The following is a description of a gene set: species: Homo sapiens part of: DAG1 glycosylations Reactome Pathway: DAG1 core M1 glycosylations Protein-linked O-mannose glycans are initiated by the covalent attachment of mannose to serine and threonine residues in the protein via alpha-linkages. Core M1 glycans consist of all O-mannose glycans in which O-mannose is extended with beta-1,2-linked N-acetylglucosamine (GlcNAc) but not with beta-1,6-linked GlcNAc. M1 structures do not directly bind key extracellular components but are essential as precursors for M2 structures, and they support the maturation of M3 glycans (Praissman & Wells 2014; Endo, 2019)., and this is the list of marker genes: DAG1, POMGNT1, POMT2, POMT1